Given this list of marker genes CRIPTO, CDC25C, DPYD, KIF2C, ZNF821, CRYBB1, IL17RB, MUC13, SYTL4 (synaptotagmin like 4), DKKL1, CTTN, LDAF1, SLC8B1, INPP5K, PYGB, TJP2, NRGN, PPP2R2D, RELL1, GRIK5, OXT, PEA15, PIAS3, LITAF, IL4R, VEGFC, ST6GALNAC1, CPD, RASGRP2, CKM, MT1E, P2RX4, FEZ2, ASB9, SLC6A9, SMCO4, WFIKKN1, ARNT2, TWIST2, TIRAP, MSRA, GATM, CMTM7, CSRP2 (NCBI Gene Id 7882), ARID3A, HOXD13, RGS1, SLC66A1, SCN4A, CA9, CEBPZOS, HBEGF, ATP2C2, ZMAT2, ARHGEF18, NPY2R, F13A1, IL18R1, PHKA2, PIM1, MAPRE2, PFKFB1, SCRG1, SOX18, ADRA2B, P2RY14, KIAA0930, BMP1, LATS2, BSN, SMOX, PROCR, SRC, B4GALT6, MMP24, TNFRSF25, DNASE1L1, PLEK2, CXCL11, MC5R, SNAI1, RDM1, DSCAML1, KIF17, VGLL1, LIPE (lipase E, hormone sensitive type), CEP89, LHX5, RFLNB, KCTD14, MIF4GD, BLK, CLSTN3, SERPINF1 (serpin family F member 1), TIFA, S100A6, NR2F6, TYROBP, DLC1, THEMIS2, PDE4A, TAL1, SPON1, NECTIN2, FAM20C (NCBI Gene Id 56975), SDC2, DTNBP1, CHEK2, HLA-C, SMS, OAS1, PLXNB2, ITSN1, GABARAPL1, KIF23, CIT, FUT7, C1R, CUEDC1, HAAO, SLC35E4, DHRS4, AQP2, MALL, PKP4, UPK2, GEM, RPS6KA2, PLPP1, RHOQ, ITGAX, CRYZL1, KRT8 (NCBI Gene Id 90177), HFE, RTP4, SEPTIN11, GM2A, PROS1, NFATC2IP, DDC, PRKAG1 (protein kinase AMP-activated non-catalytic subunit gamma 1), DCXR, CENPO, PC, MORC4, HBB, H3C4, EMC9, ART4, ENSG00000286190, PSMD13, WBP1 (NCBI Gene Id 96445), CD68, BTK, RBM43, SLC27A2, SCIN, CYGB, ZNF768, CASP4, SORBS3, ARHGAP29, ALDH2, SLC28A2, RAB17, DDAH2, IRAK4, CERS4, DAPP1, PARN, CLIC1, GBP4, SKAP2, IRF1, RPL3L, ENC1 (ectodermal-neural cortex 1), IL3RA, EPB41L4B, PMEL, AUTS2, TUBA4A, HIGD1C, RAD54L, CHDH, ANTKMT, KIF22, CD302, TLE6, TEP1, RCN3, OTULINL, KCTD11, NEXMIF, CCDC28A, CCL5, MASTL, HSD3B7, CYP4V2, PKIB, here is a description of the gene set: Development of T-cells provides a unique opportunity to study cell-fate determination due to the accessability and the well defined stages of developmental stages. In order to understand the genetic programs underlying fetal and adult T‑cell fate specification we subjected highly purified fetal and adult T-cell progenitor populations to a genome‑wide transcriptional analysis. The aim was to identify molecular elements that govern T-cell fate specification as a whole but ultimately to isolate elements that were specific for a given population in a specific developmental window. Genes up-regulated in adult DN2 thymocytes versus adult DN3 thymocytes. Human Gene Set: GSE24142_DN2_VS_DN3_THYMOCYTE_ADULT_UP studied in species Homo sapiens from publication Belyaev NN, Biró J, Athanasakis D, Fernandez-Reyes D, Potocnik AJ (PMID 22581009)